Given this list of marker genes ACVR1, SMAD1, BMPR1B, BMP6, BMP5, GDF7, BMPR1A, ACVR2A, SMAD9, ACVR2B, BMP8B, BMP7, SMAD4, BMPR2, BMP8A, BMP2, GDF5, BMP4 (NCBI Gene Id 652), GDF6, SMAD5, here is a description of the gene set: studied in species Homo sapiens Pathway Definition from KEGG: BMP -> ((ACVR2A,ACVR2B,BMPR2)+(BMPR1A,BMPR1B,ACVR1)) -> (SMAD1,SMAD5,SMAD9) == SMAD4 Human Gene Set: KEGG_MEDICUS_REFERENCE_BMP_SIGNALING_PATHWAY BMP signaling pathway. Pathway ID: N01453. Pathway type: Reference. Pathway class: nt06507 TGFB signaling.